Given this list of marker genes CAV1, CTNNB1, GSK3B, CUL3, CSNK1G1, RANBP3, PI4K2A, NKD2, DVL2, APC, PIP5K1B (phosphatidylinositol-4-phosphate 5-kinase type 1 beta), GSK3A, KLHL12, FZD5, AXIN1, DVL3, LRP6, PPP2R5A, WNT3A, DVL1, here is a description of the gene set: from publication Schaefer CF, Anthony K, Krupa S, Buchoff J, Day M, Hannay T, Buetow KH (PMID 18832364) species: Homo sapiens Canonical Wnt signaling pathway Human Gene Set: PID_WNT_CANONICAL_PATHWAY